Given this list of marker genes Havcr2, Nedd9, Lgals3, Clec2i, Ccr7, here is a description of the gene set: Mouse Gene Set: GOBP_REGULATION_OF_IMMUNOLOGICAL_SYNAPSE_FORMATION Any process that modulates the frequency, rate or extent of immunological synapse formation. species: Mus musculus